The following is a description of a gene set: species: Homo sapiens Combining with interleukin-1 to initiate a change in cell activity. Interleukin-1 is produced mainly by activated macrophages and is involved in the inflammatory response. Human Gene Set: GOMF_INTERLEUKIN_1_RECEPTOR_ACTIVITY, and this is the list of marker genes: IL1R1, IL1RAP, IL18R1, IL1R2, IL1RL1, IL1RAPL2, IL1RL2